Given this list of marker genes Pten, Adam9, Lrg1, Ppard, Krt16, Serpine1, Arf6 (NCBI Gene Id 11845), Epb41l4b, Eppk1, Fgf10, Ltb4r2, Hbegf, Map4k4, Iqsec1, Fgf7, Has2, Mtor, Fermt1, Mapre2, Krt2, Mmp9, here is a description of the gene set: The directed movement of a keratinocyte, epidermal cells which synthesize keratin, from one site to another. studied in species Mus musculus Mouse Gene Set: GOBP_KERATINOCYTE_MIGRATION